The following is a description of a gene set: Human Gene Set: REACTOME_DEVELOPMENTAL_LINEAGE_OF_MULTIPOTENT_PANCREATIC_PROGENITOR_CELLS species: Homo sapiens Developmental Lineage of Multipotent Pancreatic Progenitor Cells, and this is the list of marker genes: GATA6, FGF4, EGF, NKX6-1, FGF7, FGF10, HNF1B, HHEX, CXCR4, SOX9, SOX17, GATA4, ONECUT1, FGF2, SHH, PDX1, FOXA2, CER1